The following is a description of a gene set: studied in species Mus musculus Any process that activates or increases the frequency, rate or extent of synaptic vesicle endocytosis. Mouse Gene Set: GOBP_POSITIVE_REGULATION_OF_SYNAPTIC_VESICLE_ENDOCYTOSIS, and this is the list of marker genes: Picalm (NCBI Gene Id 233489), Mff, Snap91, Dnm1, Bcl2l1, Sh3gl1, Lrrk2, Nlgn1, Ppp3cc, Dnm1l, Abca13, Ap2m1, Tor1a